The following is a description of a gene set: Human Gene Set: MIR181C_5P studied in species Homo sapiens Genes predicted to be targets of miRBase v22 microRNA hsa-miR-181c-5p in miRDB v6.0 with MirTarget v4 prediction scores > 80 (high confidence targets). from publication Chen Y, Wang X (PMID 31504780), and this is the list of marker genes: TMEM87B, OSBPL8, PRRC2C, SIK3, WNK1, DEPTOR, WSB1, FSBP, TAB2, SLC5A9, NWD2, ZNF37A, SOWAHA, DISC1, SSX2IP, PAX9, ASPH, GTSE1, HOXA11, PLCL2, PCDHA10, IL1A, SCHIP1, NEK7, NAB1, CDKN3, TOM1L1, BRWD1, RNF34, DNAJC3, LRRC8D, KMT2A, MCC, PRTG, OGFRL1 (NCBI Gene Id 79627), ZFP62, TRIM2, ATM, SLC25A36, KANK1, PRKCD, CBLB, AP1S3, CPD, ZNF597, RAI1, ZFP36L1, MYO1E, MAPK1IP1L, PTBP3, SLITRK1, AMER2, PITPNB, BCL2 (BCL2 apoptosis regulator), TADA2B (NCBI Gene Id 93624), NOVA1, PALS1, KCNA1, LRRN1, ZNF563, SYNPR, UBE2B, SLC7A11, KATNBL1, LYRM1, APOO, KIF1B, NAA50, DCN, TNS1, HEATR3, MBOAT2, IPMK, DNAJC13 (NCBI Gene Id 285196), KLHL2, ARMC8, AFG3L2, ATP2A2, CBX7, DEK, DCLK1, NPEPPS, BCLAF1, MS4A1, BTBD3, AKAP6, TMF1, S1PR1, PTPN22, BCL2L11, PRKAG2, BAZ2B, HEY2, TM9SF4, CDON, GHITM, RASSF2, KIAA1549L, SLC35F3, ZNF121, PCDHA9, ZNF780B, WDR82, GLS, TRIM71, MIER3, BRAP, PCDHA6, HECA, TRAK1, ZNF302, CCL8, LIN28B, RIMKLB, ANKRD44, GOLGA8N, GOLGA6L4, UBE2D3, B4GALT1, IQCJ-SCHIP1, TESMIN, ETV6, CPNE2, GSE1, THRB, PAK5, FUT9, PCDHA2, TOGARAM1, PAPOLG, TBPL1, RORA, DLG2, ATP2B1, ZIC2, AGO4, SSB, GPR137C, SLC4A8, ASTN1, PCDHA4, TBC1D4, JARID2, CDYL, NAALADL2, CPOX, DUSP6, AP1G1, PNISR, GPD1L, STARD4, TCF7L2, ZNF479, SPRY4, TMEM64 (transmembrane protein 64), PCDHA7, PHACTR4, HSP90B1, ARSJ, ZNF426, POLQ, OSBPL3, PLEKHJ1, ZNRF2, NAP1L1, ADCY1, VPS41, GOLGA8J, SLAIN2, YLPM1, FNDC3B, GABRA1, ZNF124, PBX3, PNRC2, ZNF844, LCLAT1, ARMH4, ZNF780A, SYT16, TAB3, RAB3IP, IGF2BP2, SRSF7, QSER1, CHMP2B, TMEM165, ZNF468, NR4A3, NRXN1, PHIP, SPP1, TAOK1, KCNJ10, FKBP1A (NCBI Gene Id 2280), MGAT2, TBCEL, E2F7, KIF3B, ZNF544, PCDHA8, DCBLD2 (NCBI Gene Id 131566), ACAP2, PI4K2B, PABIR2, ASAH2B, KIF3A (NCBI Gene Id 11127), KLF15, SMAP1, MAN2A1, ITGA3, ADO, EYA3 (NCBI Gene Id 2140), CEP97, PCDHA12, AGFG1 (ArfGAP with FG repeats 1), CNTN4, CLIP1, TMEM131 (transmembrane protein 131), RNF182, ACER3, ONECUT2, PROX1, LIMCH1, ARHGEF3, OXGR1, AKT3, ADAM11, ATP2B2, DMXL2, TBC1D1, ST8SIA4, RAB3C, DARS1 (aspartyl-tRNA synthetase 1), CDK17, DOCK4, ZFP1 (NCBI Gene Id 162239), RLIM, C14orf28, MEGF9, CHIC1, CDH8, SELENOT, RAB3GAP1, EPHA4, PNMA2, OTUD4, FHIP1A, NCOA2, SERTAD2, ZDHHC7, ATXN3, GSKIP, BMP2K, IKZF5, AKIRIN2, RAD54B, KLHL29, RECK, MTPN, C2CD5 (C2 calcium dependent domain containing 5), PARP11, PAM, IPO7, KDM5A, ZNF268, ENAH (ENAH actin regulator), ATXN7, CECR2, ZBTB43, PEAK1, UNC80, GRIK2, PHLDA1, KMT2C, ESR1, SACM1L, TNFRSF11B, YTHDC2, PAWR, XPO7, ETNK1 (NCBI Gene Id 55500), LIN28A, SPECC1L, TNFSF4 (TNF superfamily member 4), GATA6, FNIP2, GOLGA8R, PSG11, RASSF1, CREBRF, STXBP5, NEXMIF, SPIRE1, SRGAP2, OTOGL, TMED4, ARF6, ZNF527, SAMHD1, POU2F1, KPNA1, SIPA1L2, CDC40, KLHL5, CTDSPL, MTF2, APBA1 (amyloid beta precursor protein binding family A member 1), MORC3, RASSF8, ZDHHC3, NKAIN2, GIGYF1, GRM5, IPO8, ZNF800, NOTCH4, SLC10A7, GOLGA1, TMEFF1, ADAMTS6, CD69, DYNC2H1, SLC12A5, CTTNBP2NL, SEC24A, SCD, TGFBR1, HYCC2, YTHDF3, BLOC1S6, ACVR2B, ZEB2, ENTPD6, EXOC5, LARP4, PDE3A, PRDM4, TENT4B, HCN2, ADRA1A, ATP8B2, GOT2, ATP1B1, SLC2A3, SH2B3, PDGFRA, SLC25A37, UBE2D1, LCTL, PPFIA1, PDAP1, MAP3K3, GPD2, GOLGA8H, NELFA, BEND3, CPEB4, ZBTB4, MTURN, PHF3, RALGAPB, GOLGA8M, ZNF773, ADARB1, ZNF781, OOSP2, HOXA1, TPRX1, MSANTD3-TMEFF1, PSPC1 (paraspeckle component 1), KLF6, PPP3R1, SS18L1, TRDN, MB21D2, FAM3C, CXCL9, SALL4, CNKSR3, TMLHE, ZNF584, CLVS1, TCERG1, SLC4A10, LNPK, LGALSL, PER3, ZFAND6, NIPBL, PRLR, CDC73, SLC35E1, ATXN1, PTPDC1, ST6GALNAC5, IRS2, BRD1, CNKSR2, TRDMT1, GOLGA8T, NLK, SESN3, ADAMTS18, PCDHA13, RNF217 (ring finger protein 217), FSD1L, USP42, CFAP161, PHTF2, NOTCH2, PCSK1, MYCBP2, USP33, ZNF586, NR6A1 (NCBI Gene Id 2649), ZFP90, FAM135A, FOXP1, CARM1, ZNF559, ADGRB3, KAT2B, ETS1, ARL5A, COX15, ATMIN, LIG4, CPSF6, DDX3X, TTC39B, MED26, NR1D2, EPC2, SIN3B, NLN, MUC22, KCNQ5, UBP1, ZBTB2, MYBL1, MBTPS2, HOXD1, N4BP2, CNOT2, E2F5, PLAU, INO80D, NUS1, SEC24C, CA8, NUCKS1, MUC7, LATS1, ZNF704, TNPO1, BIRC6, GOLGA8Q, HRH1, ZDHHC17, ADAMTS5, PIAS1, ZNF266, ZIC3, MTX3, LEMD3, TNRC6B, TNFAIP1, ESM1, GRB10, NCALD, RIOX2, KLHL42, GPBP1, LOX, LMO1, RAB8B, CALM1, ADCY9, HOXC8, JADE2, RPS6KB1, TBC1D14, MIDEAS, CREB1, ZNF594, UBL3, PCDHAC1, FBXO34, FBXO33, HIC2, CCNJ, G3BP2, LAMA1, BOLL, UNC5D, PCDHAC2, AP1AR, AASDHPPT, KPNB1, ETFBKMT, IGDCC3, ANKRD13C, ZNF440, PKNOX2, CALCR, PPIP5K2, MFSD6, NSUN7, NMBR, CLASP1, RFC1, GPRIN3, PARM1, IL2, PCDHA3, ZNF439, GCC2, ZFP36L2, ACSL4, TGFBRAP1, QKI, PCDHA11 (protocadherin alpha 11), KRBOX4, PAFAH1B2, ZNF140, ANO1, PHF20L1 (NCBI Gene Id 84165), ZFAND4, PCDHA5, CHMP1B, CCNK, RAB30, PPP2R3A, MBNL2, MAP2K1, TMEM144, TREML4, CDC5L, BHLHE40, C2orf69, SEMA4G, ZFP14, RYR3, CCP110, LPCAT2, TNF, ACVR2A, HAO1, FNDC3A, CHD1, PLAG1, DNAJA4, UBE3C, PDE5A, CBFA2T3 (CBFA2/RUNX1 partner transcriptional co-repressor 3), MARK1, MICU3, RLF, BAG4, ATP2B3, MLXIP, PTPN4, AKIRIN1, ZNF823, NIPAL4, PAX5, PRR27, ABTB2, PCDHA1, EYS, TXNDC12, EN1, NR2C2, RPS6KA3, CRIM1, RAD21, FGD4, RNF169, ZNF700, LPCAT1, SIX4, SLC38A11, FIGN, RBBP7, ZNF189, TCFL5, AHCTF1, REPS2, OSBPL2, HMBS, LRBA (NCBI Gene Id 987), HIPK3, TMEM94, CCNDBP1, MAMDC2, ABHD18, DERL1, AIRIM, TAFA2, KCNH1, AK9